The following is a description of a gene set: studied in species Mus musculus Mouse Gene Set: GOMF_K63_LINKED_POLYUBIQUITIN_MODIFICATION_DEPENDENT_PROTEIN_BINDING Binding to a protein upon poly-ubiquitination formed by linkages between lysine residues at position 63 in the target protein., and this is the list of marker genes: Prpf8, Uimc1, Tab3, Zbtb1, Zranb3, Wdr81, Zranb1, Ikbkg, Rnf168, Atrip, Nploc4, Tnip2, Sqstm1, Otud7b, Sprtn (SprT-like N-terminal domain), Tnfaip3 (NCBI Gene Id 21929), Tab2, Otud7a, Ascc2, Mindy2, Faap20, Optn, Parp10, Rnf31, Rnf169